Given this list of marker genes RPS29, ALG14, PKD2, RPS26, EPM2A, SPPL2C, PTPN1, ITPR3, SPPL2A, ALG13, DNAJA1, ALG2, HM13, RPS28, GNRH1, THADA, ALG1, RPL27, SPPL3, ALG5, OTULINL, EPM2AIP1, DNAJB2 (NCBI Gene Id 3300), SPPL2B, here is a description of the gene set: Human Gene Set: GOCC_CYTOPLASMIC_SIDE_OF_ENDOPLASMIC_RETICULUM_MEMBRANE The side (leaflet) of the plasma membrane that faces the cytoplasm. species: Homo sapiens